Given this list of marker genes H2BC26 (NCBI Gene Id 128312, H2B clustered histone 26), FRAT1, WNT3A, H2AC7, LEF1, H2AX, SOX3, H3C15, PIP5K1B, PPP2CA, H2AC18, DKK4, WNT4, H2BC15, TCF4, TRRAP, FZD8, DVL1, CUL3, TLE4, AKT2, PSMC5, KMT2B, H2BC21, APC, SOX4, RUNX3, WNT9A, LEO1, PPP2R5B, RSPO3, CREBBP, PSMB3, LGR4, XIAP, H2AB1, PSMD7, UBB, PSMA3, TLE1, SOX17, PPP2CB, FZD4, H2BC4, H3C1, KREMEN2, UBA52, TLE2, CBY1, AXIN2, PSMD13 (proteasome 26S subunit, non-ATPase 13), DKK2, FZD6, H3-3A, RUVBL1, RYK, WNT8A, H2BC9, MYC, FZD2, SOX2, CSNK1G2, H2BC3, YWHAZ, AXIN1, PSMB7, RNF43, XPO1, PSMB4, TLE3, HECW1, H2BC17, CHD8, USP8, DVL2, PYGO2, PSMD8, BCL9, PPP2R5C, DKK1, H2AJ, BTRC, WDR5, H2BC11, SFRP1 (NCBI Gene Id 6422), WIF1, PSMD6, PSMA7, LGR6, WNT8B, H2AZ2, PSMD2, SOX9, TCF7, PSMA6, SEM1, TNKS, PSMB2 (NCBI Gene Id 5690), EP300, WNT1 (Wnt family member 1), ZNRF3, CSNK1E, PPP2R5E, UBC, HDAC1, PPP2R5D, PSMD11, H2BC14, FZD1 (frizzled class receptor 1), LGR5, TERT, CDC73, TCF7L2, CTBP1, CSNK1A1, PSMC6, FZD5, CSNK2B, RSPO1, SMURF2, CSNK2A1, H4C1, CCDC88C, FRAT2, GSK3B, SOST, PYGO1 (pygopus family PHD finger 1), SOX6, RBX1, RSPO2, ASH2L, LRP5, RBBP5, PSMB6, PSMD1, H2BC1, PPP2R5A, RPS27A (NCBI Gene Id 6233), LRP6, AKT1, PSMA4, PSMB1, RNF146, MEN1 (menin 1), H2BC12, PSMD12, H2AC14, USP34, PSMC2, PSMA2, DPY30, WNT5A, PSMC3, PSMD14, SOX7, SRY, SFRP2, H2AC20, CTNNB1, TCF7L1, PSMB5, CTNNBIP1, BCL9L, DVL3, KAT5, SMARCA4, PPP2R1B, H2AC6, H2BC13, H2BC12L, H2AC4, AMER1, KREMEN1, PPP2R1A, PSMD3, PSMC4 (NCBI Gene Id 5704), WNT3, CAV1, RSPO4, PSMC1, DACT1, SOX13, H2BC5, ADRM1 (NCBI Gene Id 11047), TNKS2, CSNK2A2, PSMA5, PSMA1, KLHL12, H3-4, CXXC4, here is a description of the gene set: Reactome Pathway: TCF dependent signaling in response to WNT part of: Signaling by WNT 19 WNT ligands and 10 FZD receptors have been identified in human cells; interactions amongst these ligands and receptors vary in a developmental and tissue-specific manner and lead to activation of so-called 'canonical' and 'non-canonical' WNT signaling. In the canonical WNT signaling pathway, binding of a WNT ligand to the Frizzled (FZD) and lipoprotein receptor-related protein (LRP) receptors results in the inactivation of the destruction complex, the stabilization and nuclear translocation of beta-catenin and subsequent activation of T-cell factor/lymphoid enhancing factor (TCF/LEF)-dependent transcription. Transcriptional activation in response to canonical WNT signaling controls processes such as cell fate, proliferation and self renewal of stem cells, as well as contributing to oncogenesis. studied in species Homo sapiens